Given this list of marker genes Anxa8, Eif2d, Ccng1, Prdx2, Cfh, Crabp2, here is a description of the gene set: from publication Castellano E, De Las Rivas J, Guerrero C, Santos E (PMID 16909116) We characterized differential gene expression profiles of fibroblast cell lines harboring single or double-homozygous null mutations in H-ras and N-ras. Whereas the expression level of the individual H-, N- and K-ras genes appeared unaffected by the presence or absence of the other ras loci, significant differences were observed between the expression profiles of cells missing N-ras and/or H-ras. Absence of N-ras produced much stronger effects than absence of H-ras over the profile of the cellular transcriptome. N-ras(-/-) and H-ras(-/-) fibroblasts displayed rather antagonistic expression profiles and the transcriptome of H-ras(-/-) cells was significantly closer to that of wild-type fibroblasts than to that of N-ras(-/-) cells. Classifying all differentially expressed genes into functional categories suggested specific roles for H-Ras and N-Ras. It was particularly striking in N-ras(-/-) cells the upregulation of a remarkable number of immunity-related genes, as well as of several loci involved in apoptosis. Reverse-phase protein array assays demonstrated in the same N-ras(-/-) cells the overexpression and nuclear migration of tyrosine phosphorylated signal transducer and activator of transcription 1 (Stat1) which was concomitant with transcriptional activation mediated by interferon-stimulated response elements. Significantly enhanced numbers of apoptotic cells were also detected in cultures of N-ras(-/-) cells. Our data support the notion that different Ras isoforms play functionally distinct cellular roles and indicate that N-Ras is significantly involved in immune modulation/host defense and apoptotic responses. studied in species Mus musculus Mouse Gene Set: CASTELLANO_HRAS_AND_NRAS_TARGETS_UP Genes up-regulated in MEF cells (embryonic fibroblasts) isolated from HRAS and NRAS double knockout mice.